The following is a description of a gene set: Mouse Gene Set: GOBP_ADRENERGIC_RECEPTOR_SIGNALING_PATHWAY studied in species Mus musculus A G protein-coupled receptor signaling pathway initiated by a ligand binding to an adrenergic receptor on the surface of a target cell, and ending with the regulation of a downstream cellular process., and this is the list of marker genes: Gnas, Arrdc3, Gsk3a, Gnai2, Adrb2, Adrb3, Drd5, Gpr88, Zdhhc21, Pde4d, Adra2a, Adra2c, Rapgef2, Kcnq1, Gpr101, Adra1b, Adrb1, Adra2b, Adra1d, Adra1a, Rgs2, Akap13, Nos1 (nitric oxide synthase 1, neuronal), Pln, Chga, Lmbrd2, Crtc3, Adcy9, Drd1, Atp2b4